The following is a description of a gene set: Mouse Gene Set: CUI_LANGERHANS_GM_CSF_RESPONSE_DN Genes negatively differentially expressed in cell type: Langerhans upon treatment with cytokine: GM-CSF in mouse lymph nodes in vivo. Cytokines mediate cell-cell communication in the immune system and represent important therapeutic targets. A myriad of studies have highlighted their central role in immune function, yet we lack a global view of the cellular responses of each immune cell type to each cytokine. To address this gap, the authors created the Immune Dictionary, a compendium of single-cell transcriptomic profiles of more than 17 immune cell types in response to each of 86 cytokines (>1,400 cytokine-cell type combinations) in mouse lymph nodes in vivo. A cytokine-centric view of the dictionary revealed that most cytokines induce highly cell-type-specific responses. For example, the inflammatory cytokine interleukin-1β induces distinct gene programmes in almost every cell type. A cell-type-centric view of the dictionary identified more than 66 cytokine-driven cellular polarization states across immune cell types, including previously uncharacterized states such as an interleukin-18-induced polyfunctional natural killer cell state. species: Mus musculus from publication Cui A, Huang T, Li S, Ma A, Pérez JL, Sander C, Keskin DB, Wu CJ, Fraenkel E, Hacohen N (PMID 38057668), and this is the list of marker genes: Tmem123, Slc6a6, Il7r, Ighm, Cxcl16, Tnfrsf1b, Ostf1, Tspo, Kctd12, Cblb, Tspan33, Spred1, Epsti1, Cd207, Lad1, Ankrd35, Creg1, Haus8, Sat1, Traf1, Cd52, Tmem176a, Brk1, Mx1, Iscu, Micu1, Synpo2, Ubb (ubiquitin B), Ctsh, Tmem150c, Il4i1, Mfge8, Parp8, Tapbpl, Asprv1, Slc38a2, Apol7c, Tspan3, Plxnc1, Gins3, Gramd2b, Lsp1, Tank, Mxd1, Pfkfb3, Irf8, Specc1, Chka, Atxn1, Relb, Dusp2, Tmem176b, Trio, Icosl, Arl5c, Hebp1, Gadd45b, Castor2, Evi2a, Itm2c, Nav1, Rcsd1, Fam53b (NCBI Gene Id 77938), H3f3a